Given this list of marker genes CSPG4, GPC2, GPC1, BCAN, B3GAT3, BGN, DCN, SDC4 (syndecan 4), CSPG5, SDC3, HSPG2, SDC1, GPC5, SDC2, GPC3, VCAN, GPC6, GPC4, NCAN, AGRN, here is a description of the gene set: studied in species Homo sapiens part of: Diseases associated with glycosaminoglycan metabolism Galactosylgalactosylxylosylprotein 3-beta-glucuronosyltransferases1, 2 and 3 (B3GAT1-3) are involved in forming the linker tetrasaccharide present in heparan sulfate and chondroitin sulfate. Defects in cause multiple joint dislocations, short stature, craniofacial dysmorphism, and congenital heart defects (JDSSDHD; MIM:245600). This is an autosomal recessive disease characterized by dysmorphic facies, elbow, hip and knee dislocations, clubfeet, short stature and cardiovascular defects (Steel & Kohl 1972, Bonaventure et al. 1992, Baasanjav et al. 2011). JDSSDHD has phenotypic similarities to Larsen syndrome. Reactome Pathway: Defective B3GAT3 causes JDSSDHD